The following is a description of a gene set: studied in species Mus musculus from publication Sansom OJ, Meniel VS, Muncan V, Phesse TJ, Wilkins JA, Reed KR, Vass JK, Athineos D, Clevers H, Clarke AR (PMID 17377531) Genes down-regulated after double Cre-lox knockout of both APC and MYC in small intestine. Mouse Gene Set: SANSOM_APC_MYC_TARGETS The APC gene encodes the adenomatous polyposis coli tumour suppressor protein, germline mutation of which characterizes familial adenomatous polyposis (FAP), an autosomal intestinal cancer syndrome. Inactivation of APC is also recognized as the key early event in the development of sporadic colorectal cancers, and its loss results in constitutive activity of the beta-catenin-Tcf4 transcription complex. The proto-oncogene c-MYC has been identified as a target of the Wnt pathway in colorectal cancer cells in vitro, in normal crypts in vivo and in intestinal epithelial cells acutely transformed on in vivo deletion of the APC gene; however, the significance of this is unclear. Therefore, to elucidate the role Myc has in the intestine after Apc loss, we have simultaneously deleted both Apc and Myc in the adult murine small intestine. Here we show that loss of Myc rescued the phenotypes of perturbed differentiation, migration, proliferation and apoptosis, which occur on deletion of Apc. Remarkably, this rescue occurred in the presence of high levels of nuclear beta-catenin. Array analysis revealed that Myc is required for the majority of Wnt target gene activation following Apc loss. These data establish Myc as the critical mediator of the early stages of neoplasia following Apc loss., and this is the list of marker genes: Gas8, Cenpa, Trim7, Mdn1, Sapcd2, Prrc2c, Slc6a6, Eif2ak3, Ndst1, Sema4d, Smarcc1, Tm9sf3, Telo2, Hsp90ab1, Zbtb48, Rad23a, Zkscan8, Cdx2, Mcm7, Bdnf, Lig3, Med22, Ctdsp2 (CTD small phosphatase 2), Oxr1, Rbks, Sema3b, Dhcr24, Cfap410, Ddx49, Psmb9, Ywhag, Mif, Sdc1, Pias4, Zfp444, Pkn3, Wdr4, Commd9, Dennd6b, Fhod1, Skic3, Ints1, Nelfa, Bcas3, Fzd5, Cox10, Fam83g, Ldah, Fmr1, Ror2 (receptor tyrosine kinase-like orphan receptor 2), Arfgef1, Colgalt1, Mrpl38, Pole, Atmin, Trappc6a, Myc, Foxm1, Yae1d1, Adissp, Nubp2, H3c1, Ttc27, Nme1, Ing4, Smpd4, Mindy1, Mcm3 (minichromosome maintenance complex component 3), Ikbkg (inhibitor of kappaB kinase gamma), Tnfrsf12a, Tkt, Sfswap, Qtrt1, Pofut1, Acer2, Tfrc, Sigmar1, Pip5k1a, Card11, Lims1, Usp20, Kat2a, Siva1, Vps51, Nol9, Atp2a3, 4930503L19Rik, Wdr62, Psrc1, Tmem141, Bcl7c, Txlna, Tubb2a, Cinp, Cct4, Yju2, Trp53rkb, Plk3 (NCBI Gene Id 12795), Snrpf, Knstrn, Shmt2, Exosc1, Tgif2, Bmp7, Ssx2ip (SSX family member 2 interacting protein), Exd2, Akt1s1, Nol8, Pmf1 (polyamine-modulated factor 1), Bcl2l1, Prpf19, Gtf2i, Nfkbil1, Jade1, Tfip11, Ptprs, Atl2, Neurog3, Taf7, Kptn, Sec61a1, Eif4g1 (NCBI Gene Id 320196), Shmt1, Ccser2, Pabpc4 (NCBI Gene Id 230721), Dnm1l, Fads3, Zfp64, Vars1, Hnf1b, Gtpbp3, Wdr33, Fem1b, Rnf38, Nfkb2, Ankrd39, Ier5, Ccnd1, Phgdh, Homer1, Large2, Ntmt1, Gorasp1, Lhpp, 1110019D14Rik, Hipk1, Zfp2, Txnrd2, Lfng, Sf3b5, Impdh2, Mvk, Zfp213, Srsf2, Zmynd19, Mthfd1, Ticrr, Hspbap1, Cited1, Mccc2, Ado, Mybbp1a, Trmt6, Dcun1d3, Igf2, Ache, Hira, Dkc1, Rrp9, Wipi2, Ctbs, Sart3, Acp3, Men1, Ube2k, Pxn, Alkbh2, Atf6, Acer1, Ogfod1, Pmm1, Atic, Krtap21-1, Mapk7, Zfp28, Slc1a3, Ercc4, Gtf3c1, Oplah, Sytl1, Nhp2, Scamp4, Sh3d19, Abhd14a, Ndrg1, Dnmbp, Atrip, Mettl1, Scrn2, Thop1, Sfxn2, Vipr1, Abcc10, Usf1, Klf6 (Kruppel-like transcription factor 6), Txn2, Ogfr, Abcb8, Nbeal2, Sox4, Sgcb, Dph2, Impact (NCBI Gene Id 319442), Tbc1d15, Epb41, Rassf4, Dock9 (dedicator of cytokinesis 9), Ubald1, Ammecr1, Ppp1r15b, Gemin5, Dag1, Nptx2, Zbtb21, Trp53, Bivm (NCBI Gene Id 98474), Lmnb2, Vezt, Ldb1, Pola2, Ascl2, Cxxc1, Otub1, Arhgef12, Crebbp, Slc35b2, Nsd1, Cdc42bpa, Get1, Nub1 (negative regulator of ubiquitin-like proteins 1), Coro1c, 4930412F09Rik, Nfic